The following is a description of a gene set: Any process that activates or increases the frequency, rate or extent of vascular associated smooth muscle cell migration. species: Homo sapiens Human Gene Set: GOBP_POSITIVE_REGULATION_OF_VASCULAR_ASSOCIATED_SMOOTH_MUSCLE_CELL_MIGRATION, and this is the list of marker genes: DOCK7, MIR146A, FGF9, FAT1, PDGFB, DDR2 (NCBI Gene Id 4921), TERT, ADAMTS1, DOCK4, MIR143, MIR451A, MIR302C, MIR21, MIR499A, MIR221, MIR26A1, IGFBP5 (NCBI Gene Id 3488), SSH1, DOCK5, MDM2, MAP3K7, PAK1, MIR448, MIR135B, NR4A3, MIR20A, XBP1